The following is a description of a gene set: Human Gene Set: HP_ABNORMAL_CEREBELLAR_VERMIS_MORPHOLOGY Abnormal cerebellar vermis morphology An anomaly of the vermis of cerebellum. species: Homo sapiens, and this is the list of marker genes: TCTN1, CEP120, CCDC32, SLC35A2, SCO2, SLC25A19, MAGEL2, TUBB4B, B4GALT1, KPNA3, TUBB3, RERE, CACNA1A, GPC4, EBF3, ARHGEF2, RPGRIP1, CPLANE1, SEMA3E, RAP1B, RPE65, IMPDH1, PAFAH1B1, COG3, SETX, GPC3, BRF1, ARID1A, AHI1, FKTN, RDH12, DHCR7, TRAPPC9, EXOSC8, ATP6V0A2, SRPX2 (sushi repeat containing protein X-linked 2), EXOC2, CENPF, ASXL3, KIF1A, PACS2, FOXC1, TSEN15, PRDM13, SACS, PHGDH, CEP41, MPL, QARS1, POMT1 (NCBI Gene Id 10585), L1CAM, SPATA7 (NCBI Gene Id 55812), NRAS, KCNQ1OT1, PIGU, TULP1, USP9X, FA2H, FGFR1, TAF1, POLR1A, POLR3B, SMARCC2, ITPR1, SYT14 (NCBI Gene Id 255928), IFT140, CUL4B, ZEB2, SMARCD1, INTS1, CDKN1C, GRIA3, TBC1D24, GJB2, PRKDC, ACBD6, KIF21A, TBC1D20, LARGE1, HYLS1, ALG3 (ALG3 alpha-1,3- mannosyltransferase), ATR, RARS2, ASXL1, ADGRG1, GOT2, CSPP1, ESCO2, KIAA0753, CRPPA, LAMA1, VLDLR, LNPK, POMK, KCNQ1, APC2, CPSF3, TSEN2, PIGS, DCHS1, B9D2, TMEM107, OPHN1, TRPC3, TMEM67, BICD2, TCTN3, PSAT1, PGAP2, DOK7, SUFU (SUFU negative regulator of hedgehog signaling), ATP9A, TMEM216, ACY1, B9D1, SEPSECS, RBM10 (RNA binding motif protein 10), TRRAP, FIG4, TMEM138, SRD5A3, ARL13B, MBD5, CSF1R, KATNIP, GRID2, CHD7, RFC1, ARID2, TXNDC15, BUB1B, RAB11B, COQ4, THOC2, AFF3, ATP6V1A, HMBS, GJB1, XRCC4, RAB3GAP1, ARF1, LMX1B, HRAS, MEF2C, DYNC2I1, ALX4, TMEM237, NPHP1, RXYLT1, TUBA1A, DPF2, ATXN1 (NCBI Gene Id 7912), TDP1, PIGN, PEX2, IGF2, CRB1, NPHP3, FOSL2, POMGNT2, MUSK, CEP290, PDE6D, LETM1, ODC1, SMARCB1, TOGARAM1, MAST1, CEP57, FAR1, LAMB1, TUBB2B, ZIC1, SMG9, EVC, PGAP1, CHP1, TCTN2, PIEZO2, DYNC2H1, KCNJ13, GUCY2D, TMCO1, ENSG00000288330, TRIP13, TAF4, RAC1, DPH1, VPS41, ZNF423, PCGF2 (polycomb group ring finger 2), DDX3X, CNTNAP2, ATXN8OS, PPP1R21, FTO, ARID1B, MYOD1, PIK3R5, LRPPRC (NCBI Gene Id 10303), VPS51, RNU4ATAC, TOPORS, CC2D2A, CEP164, TSEN54, POMGNT1, VPS35L, TMEM218, GRM1, ASNS, ATP6V1E1, NPTX1 (neuronal pentraxin 1), NSD1, SCYL1, GTPBP2, NOP56, MAN2C1, CHD8 (chromodomain helicase DNA binding protein 8), FRMD4A, ADPRS, SOX11, CAPN1, RNF113A, TSEN34, ELOVL5, IFT74, HHAT, CRX, STXBP1, RNU12, SYT2, DAB1, NUP88, SOX4, KIAA0586, RBM8A, DENND5A, NMNAT1 (NCBI Gene Id 64802), PNPLA6, PIBF1, PPP1CB, PI4KA, RAB18, ROBO1, KNL1, DPYSL5, PTEN, WDR81, SASS6, KRAS, MAB21L1, NSRP1, WDR4, CDC42, PACS1, MID1, B4GAT1, SLC18A3, WDR73, RD3, COG1, BMP4, TUBB, PCYT1A, WLS, ATP6V1B2 (ATPase H+ transporting V1 subunit B2), TMEM240, NEK1, PEX16, AP1S2, GLI3, BCOR, COL4A1, ATP2B3, FAT4, WARS2, EPG5, PMPCA, KIF7, C2CD3, LCA5, IQCB1, DPH5, HNRNPR (heterogeneous nuclear ribonucleoprotein R), ARMC9, TFAP2A, RAPSN, PLP1, VPS4A, COX20, GMPPB, NCAPG2, PMM2, TUBB2A, SMARCE1, CCDC22, CPT2, DYNC2I2, NUP37, FDXR, EVC2, POGZ, EBP, B3GALNT2, FLVCR2, MED11, OPA1, WASHC5, GJB6, PPFIBP1, CEP104, ATN1, USP45, THG1L (NCBI Gene Id 54974), MAPKAPK5, KIF5A, LRRC32, WDR35, POLR3A, MYO5A, MARS2, FKRP, HNRNPH1, CWF19L1 (NCBI Gene Id 55280), AIPL1, PRKCG, CACNA1G, H3-3A, RFX7, POMT2 (NCBI Gene Id 29954), IFT80, DPH2, RPGRIP1L (RPGRIP1 like, NCBI Gene Id 23322), CDC42BPB, OFD1, KIF14, BCL11A, COG8, RAB3GAP2, EIF4A2, INPP5E, MVK, DAG1, SLC25A24, FAM149B1, NSUN6, LRAT, HTT, MKS1, SEMA6B, SIL1, SLC39A8, BLTP1, ARL3, CBY1 (NCBI Gene Id 25776), WWOX, SMARCA4, SLC9A1, MTM1, IFT172, CACNA2D2, MRE11, DYNC1H1, BUB1, BUB3, TBCK, MACF1, PTF1A, PLCH1, MDH1, DLG4, PLG, TMEM231, GEMIN4, CLXN, MME, GDF6